Given this list of marker genes Shank3, Foxp2, Nrxn1, Nrxn2, D130043K22Rik, Htt, Cntnap2, Stra6, here is a description of the gene set: species: Mus musculus A behavioral process whose outcome is a relatively long-lasting behavioral change whereby an organism modifies innate vocalizations to imitate sounds produced by others. Mouse Gene Set: GOBP_VOCAL_LEARNING